The following is a description of a gene set: The directed movement of substances that are in liquid form in normal living conditions into, out of or within a cell, or between cells, by means of some agent such as a transporter or pore. Human Gene Set: GOBP_FLUID_TRANSPORT species: Homo sapiens, and this is the list of marker genes: AHCYL1, AQP1, SCNN1B, AQP12B, ITPR1, INPP5K, AQP5, NHERF4, CSF2, AQP7B, EDNRB, AQP4, SLC5A1, CLDN18, AQP2, AQP7 (aquaporin 7), UPK3A (NCBI Gene Id 7380), EXT2, SLC26A6, MLLT6, AQP11, CFTR, AQP6, HAS2, AQP9, PKP1, MIP, PDPN, AVP, LARGE1, AQP3, HYAL2, AQP10, SLC4A11, AQP12A, SLC14A1, EXT1, EDN1, AQP8